The following is a description of a gene set: studied in species Mus musculus Mouse Gene Set: GOCC_DENSE_CORE_GRANULE_MEMBRANE The lipid bilayer surrounding a dense core granule., and this is the list of marker genes: Cadps, Stxbp5, Syt5, Actn1, Aqp1, Kif1a, Slc18a2, Vps13c, Adam8, Syt4